The following is a description of a gene set: studied in species Mus musculus Mouse Gene Set: GOBP_CELLULAR_RESPONSE_TO_ACIDIC_PH Any process that results in a change in state or activity of a cell (in terms of movement, secretion, enzyme production, gene expression, etc.) as a result of a pH stimulus with pH < 7. pH is a measure of the acidity or basicity of an aqueous solution., and this is the list of marker genes: Slc9a1, Asic2, Scnn1a, Kcnk1 (NCBI Gene Id 212682), Rab11fip5, Scnn1b, Trpv1, Kcne1, Kcnk3, Scnn1g, Chp1, Pkd1l3, Rab11b, Kcnk4, Kcnk9, Pkd2l1